Given this list of marker genes Ccng1, Cdk1, Ppp2r1b, Phf20, Chek2, Pdpk1, Ubb, Trp53, Daxx, Sgk1, Rps27a, Ccna1, Rictor, here is a description of the gene set: This event has been computationally inferred from an event that has been demonstrated in another species.<p>The inference is based on the homology mapping from PANTHER. Briefly, reactions for which all involved PhysicalEntities (in input, output and catalyst) have a mapped orthologue/paralogue (for complexes at least 75% of components must have a mapping) are inferred to the other species. Reactome Pathway: Regulation of TP53 Expression and Degradation part of: Regulation of TP53 Activity electronically inferred by orthology from the curated human pathway species: Mus musculus